The following is a description of a gene set: Any process that modulates the frequency, rate or extent of protein K63-linked ubiquitination. Mouse Gene Set: GOBP_REGULATION_OF_PROTEIN_K63_LINKED_UBIQUITINATION species: Mus musculus, and this is the list of marker genes: Birc2, Ube2v2, Gps2, Ube2n (ubiquitin-conjugating enzyme E2N), Ube2v1, Nod2, Parp10, Plaa, Ripk2, Cep63, Ddx3x, Sash1, D1Pas1, Ptpn22